The following is a description of a gene set: Genes that correlated most highly with left ventricular mass (LVM) index. Human Gene Set: PETRETTO_CARDIAC_HYPERTROPHY species: Homo sapiens Left ventricular mass (LVM) and cardiac gene expression are complex traits regulated by factors both intrinsic and extrinsic to the heart. To dissect the major determinants of LVM, we combined expression quantitative trait locus1 and quantitative trait transcript (QTT) analyses of the cardiac transcriptome in the rat. Using these methods and in vitro functional assays, we identified osteoglycin (Ogn) as a major candidate regulator of rat LVM, with increased Ogn protein expression associated with elevated LVM. We also applied genome-wide QTT analysis to the human heart and observed that, out of 22,000 transcripts, OGN transcript abundance had the highest correlation with LVM. We further confirmed a role for Ogn in the in vivo regulation of LVM in Ogn knockout mice. Taken together, these data implicate Ogn as a key regulator of LVM in rats, mice and humans, and suggest that Ogn modifies the hypertrophic response to extrinsic factors such as hypertension and aortic stenosis. from publication Petretto E, Sarwar R, Grieve I, Lu H, Kumaran MK, Muckett PJ, Mangion J, Schroen B, Benson M, Punjabi PP, Prasad SK, Pennell DJ, Kiesewetter C, Tasheva ES, Corpuz LM, Webb MD, Conrad GW, Kurtz TW, Kren V, Fischer J, Hubner N, Pinto YM, Pravenec M, Aitman TJ, Cook SA (PMID 18443592), and this is the list of marker genes: FN1, NID1, ST3GAL6, MFAP5, TUBA1A, CPNE3, TUBA1C, ACTA2, LPL, CRIM1, TAGLN, ENPP2, COL5A2, LOXL1, ANXA1, OSBPL8, SNAP23, ELP5, RTN4, FBN1, EFEMP1, FSTL1, ACTB, ABAT, ASPN (asporin), CD44, IGFBP3, OGN (NCBI Gene Id 4969), TM4SF1, PDLIM3, LTBP3, ARID5B, ANXA4, DDX3X